Given this list of marker genes Gmfg, Xcl1, Btg1 (BTG anti-proliferation factor 1), Ubc, Hmgb2, Klf6, S100a10, Shisa5, H2az1, Il18r1, Fos, Btg2, Sell (NCBI Gene Id 98392), Dusp1, Klf2, Lsp1, Ccl5, Cd9, Itgb1, Ahnak, Jun, Tyrobp, Malt1, Ltb, Traf1, Tsc22d3, Neurl3, Junb, Crip1, Cd7, Zfp36l2 (NCBI Gene Id 12193), Anxa1, Anxa2, Emb, Ctla2a, Limd2, Myo1f, Jak1, Cd2, Klhl6, Il18rap, Cox7a2l, here is a description of the gene set: species: Mus musculus Mouse Gene Set: CUI_NK_CELL_IL4_RESPONSE_DN Cytokines mediate cell-cell communication in the immune system and represent important therapeutic targets. A myriad of studies have highlighted their central role in immune function, yet we lack a global view of the cellular responses of each immune cell type to each cytokine. To address this gap, the authors created the Immune Dictionary, a compendium of single-cell transcriptomic profiles of more than 17 immune cell types in response to each of 86 cytokines (>1,400 cytokine-cell type combinations) in mouse lymph nodes in vivo. A cytokine-centric view of the dictionary revealed that most cytokines induce highly cell-type-specific responses. For example, the inflammatory cytokine interleukin-1β induces distinct gene programmes in almost every cell type. A cell-type-centric view of the dictionary identified more than 66 cytokine-driven cellular polarization states across immune cell types, including previously uncharacterized states such as an interleukin-18-induced polyfunctional natural killer cell state. from publication Cui A, Huang T, Li S, Ma A, Pérez JL, Sander C, Keskin DB, Wu CJ, Fraenkel E, Hacohen N (PMID 38057668) Genes negatively differentially expressed in cell type: NK cell upon treatment with cytokine: IL-4 in mouse lymph nodes in vivo.